Given this list of marker genes Snrpc, U2af2, Snrpd3, Prpf39, Snrpd1, here is a description of the gene set: studied in species Mus musculus Mouse Gene Set: GOCC_COMMITMENT_COMPLEX A spliceosomal complex that is formed by association of the U1 snRNP with the 5' splice site of an unspliced intron in an RNA transcript.